Given this list of marker genes Cyfip1, Trpc6, Arpp21, Pcdh8, Camta1, Zfp516, Elovl5, Treml2, Fndc3a, Pfkfb2, Pdzrn4, Ap1ar, Nxpe3, Insyn2a, Irag1, Car10 (NCBI Gene Id 72605), Gcnt4, Gabrb3, Il18r1, 3425401B19Rik, Oxgr1, Epas1, Gatc, Lcn10, Stard8, Prlr, Tmem196, Xlr, Stox2, Atrx, Zfp729b, Pou4f2, Zfand3, Gm14296, Larp4, Map10, Sh2d2a, Adcyap1, Fech, Pcmtd1, Vps33b, Trim12c, Tmem47, Gxylt1 (NCBI Gene Id 382997), Retn, Xrcc3, Pcsk2, Vamp5, Kpna3, Sox5, Syn3, Nlgn3, Fbxo43, Star, Rgs17, Zfp91, Cdcp3, Kcne2, Nol12, Elfn1, Chml, Tasp1, Tesmin, Kansl1l, Fsd1l, D630023F18Rik, Gpr82, Armc1, Gpm6a, Fgf14, Cps1, Ints8, Gnb4, Rbpms, Krtap4-21, Slc6a19, Tead1, Krtap4-20, E2f8, Prc1, Tmem144, P2ry13, Sh3bgrl2, Sema3a, Septin10, Mill1, Crkl, Klhl13, Foxp3, Phf20l1, Zfp92, Pla2r1, Onecut2, Fam180a, Idh3b, Lhfpl6, Nhsl2, Cat, Ano3, Rock2, Sh3rf3, Dera, Enpp2, Arhgef9, Ankrd29, Onecut3, Map3k20, Uck2, Slco3a1, Nr3c1, Mmp20 (matrix metallopeptidase 20 (enamelysin)), Rrm2b, Adcy9, Bach2, Zfp936, Zfp931, Krtap4-13, Mylk4, Zfp595, Eda2r (NCBI Gene Id 279598), P4ha3, Rsph4a, Bean1, Ssbp4, Musk, Gimap9, Lnx2, Cplx2, Chst11, Spr, Rslcan18, Mycbp, Rab7, Iglon5, Zfp1009, Etf1, Zfp971, Acvr2b, Ttc9, Septin3, Inhbb, Elovl6 (ELOVL fatty acid elongase 6), Gtf2h2 (general transcription factor II H, polypeptide 2), Hexim1, Gria3, Rbms3, Aldh1l2, Timm21, Dmrtc1a, Vegfa, Pou3f4, Rab9b (NCBI Gene Id 319642), Adal, Ttc39a, P2rx7, Neu1, Rab11fip1, Kpna1, Adgra1, Cd33, Triobp, Olr1, Cckar, Gcnt2, Slco2a1, Zfyve16, Nfat5, Rspo1, Tc2n, Extl3, Gm2026, Il1rap, Vsig10l, Cipc, Trmt2b, Pafah1b1, Gm14325, Lamp2, Klf6, Cd4, Dusp7, Zfp46, 2210418O10Rik, Arhgef10, Acbd5, Tshz1, Cop1, Abraxas1, Enpp1, Them7, Napb (N-ethylmaleimide sensitive fusion protein attachment protein beta), Pirt, Enpp6, Fam169b, Itga4, Zfp935, St18, Setd3, Sowahc, Lck, Tcte1, Pitpnb, Fezf1, Atrn, Nox4, Cgas, Papss2, Acot3, Galnt13, Gpr132, Scfd1, Amotl1, Pstpip2, Brwd3, Fmn2, Ccpg1, Tcp1, Ccdc93, Scai, Rdh19, Prkcd, here is a description of the gene set: Genes predicted to be targets of miRBase v22 microRNA mmu_miR_466a_5p, mmu_miR_466p_5p in miRDB v6.0 with MirTarget v4 prediction scores > 80 (high confidence targets). species: Mus musculus Mouse Gene Set: MIR_466A_5P_MIR_466P_5P from publication Chen Y, Wang X (PMID 31504780)